Given this list of marker genes SERPINE1, NIP7, CD84, ARHGAP45, CXXC4-AS1, HBEGF, GMEB1, ATP2C1, DCTN5, CENPBD2P, KIF2A (NCBI Gene Id 3796), LRR1, GTF2F1, CTTN (NCBI Gene Id 2017), POC5, GTF3C6, APEX2, HERC2P9, RCHY1, TMEM91, DAPP1, NOP16, MADD, EHD3, PMAIP1, RAB38, MKRN1, TMEM140, PLEK, STK24, ARID3B, MED12L, CMTM6, VCL, TP53RK, PPP1R15A (protein phosphatase 1 regulatory subunit 15A), SPACDR, LOXL3, SPX, LINC02977, APMAP, ILK, COQ10B, BLTP3A, RAB32, F11R, GALNT7-DT, XPNPEP1, RAP1B, SLC30A5, DENND2C, MST1R (NCBI Gene Id 5755), EFHC2, IGBP1, WDR1, PTPRT, CNST, MGAT4B, NMT1, XNDC1N, CLDN15, COPRS, ASNSD1, CDIPT, ITGB3, APBB1, EWSAT1, PANK2, PROSER2, NARS1, GAS2L1, ENDOG, SAMD14, ZNF48, MRPL27, HNRNPLL, FAM234A, ECHDC1, ARMCX3, REEP4, LINC02018, HTATSF1 (NCBI Gene Id 27336), SERPINI1, LRRC8B (leucine rich repeat containing 8 VRAC subunit B, NCBI Gene Id 23507), GTF3C2, TMEM62, PRKAR2B, GNAZ, FCGR2A, UBE2J1, HTR2A, DSCAML1, ATE1OSP, P2RX1, TMEM256, SOCS3, MAX, MTMR9 (NCBI Gene Id 83651), WDR11-DT, PTGIR (prostaglandin I2 receptor), ABI3 (ABI family member 3), USB1, TUBB1, TTC9C, SLC9A1, H2AC6, MTCP1, SH3BGRL2, SLC2A3, TUBA4A, PSMB10, RAP2B, BICRA, ALOX12, NFKBIA, TIPIN, IRS2, TDP2 (NCBI Gene Id 51567), C12orf43, ATP2B2, MID1IP1, CHERP, RGS18, PPIF, CAVIN2-AS1, PTGS1, CA2, RUFY1, XRCC2, MAPKAPK3, PSAT1, SDC4, RILP, SIAE, DCUN1D1, ENOPH1, KIFC3 (NCBI Gene Id 3801), CDC16, ZYX, PSME2, PIF1, SYTL4, SLFN13 (NCBI Gene Id 146857), GLMN (NCBI Gene Id 11146), THBS1, SLC50A1, N6AMT1, CHST2, C4orf33, UNC45A, ZNF431, ANKRD37, TMEM40, RAB27B, FAM131B-AS2, YWHAH, USP21, DEPP1 (DEPP autophagy regulator 1), DENND6B, STX11, UNC13D, P2RY1, ANKRD9, F2RL3, COL24A1 (collagen type XXIV alpha 1 chain), LINC01003 (NCBI Gene Id 100134539), CHCHD1, ELOVL7, CASTOR3P, NRGN, FABP5, FXYD5, MAFG (NCBI Gene Id 84797), NDUFB3, CTSA, PF4, UMPS, CLU, E2F1, OARD1, SPINT2, TOLLIP, SIX2, CSNK1D (casein kinase 1 delta), SLC39A8, TLN1, MEIS1, MRPL43 (mitochondrial ribosomal protein L43), ITGA2B, MFAP3L, CD226, DCLRE1A, PRKCQ-AS1, SIVA1, ZNF367, SNHG30, LIPH, TMED8, APOBEC3F, CPXM1 (carboxypeptidase X, M14 family member 1), LINC01762, SLC24A3, DR1, LYL1, MIR9-2HG, GP6, SORT1, LZIC, PATL2, RIT1, TPTEP1, AKR7A2, GNAQ, DGKG, PLCXD1, PGAM1P8, SV2A, DNM3, ASL, BIN2, CCPG1, BYSL, ZNF487, SLC66A1LP, TALDO1, ANKMY1, SOD1, TMCO1, SELP, MOSPD1, SLC37A1, SOCS2-AS1, CAMK1, KLHL6, EFCAB13-DT, MDM1, MCM6, LTBP1 (NCBI Gene Id 4052), TSFM, LINC01473, here is a description of the gene set: The gene expression program underlying the specification of human cell types is of fundamental interest. The study authors generated human cell atlases of gene expression and chromatin accessibility in fetal tissues. For gene expression, the study authors applied three-level combinatorial indexing to >110 samples representing 15 organs, ultimately profiling ~4 million single cells. The study authors leveraged the literature and other atlases to identify and annotate hundreds of cell types and subtypes, both within and across tissues. Our analyses focused on organ-specific specializations of broadly distributed cell types (such as blood, endothelial, and epithelial), sites of fetal erythropoiesis (which notably included the adrenal gland), and integration with mouse developmental atlases (such as conserved specification of blood cells). These data represent a rich resource for the exploration of in vivo human gene expression in diverse tissues and cell types. from publication Cao J, O'Day DR, Pliner HA, Kingsley PD, Deng M, Daza RM, Zager MA, Aldinger KA, Blecher-Gonen R, Zhang F, Spielmann M, Palis J, Doherty D, Steemers FJ, Glass IA, Trapnell C, Shendure J (PMID 33184181) Human Gene Set: DESCARTES_FETAL_MUSCLE_MEGAKARYOCYTES studied in species Homo sapiens Marker genes curated from the annotated cluster as represented in the Descartes Human Gene Expression During Development database.